Given this list of marker genes PSMB10 (NCBI Gene Id 8138), PSMA2, PSMB5, PSMA4, PSMB4, PSMB3, PSMB7, PSMB2, PSMA5, PSMB1, PSMA1, PSMA7, PSMA3, here is a description of the gene set: Human Gene Set: MODULE_50 studied in species Homo sapiens Genes in the cancer module 50.